The following is a description of a gene set: Mouse Gene Set: GOBP_REGULATION_OF_MYELOID_CELL_DIFFERENTIATION Any process that modulates the frequency, rate or extent of myeloid cell differentiation. species: Mus musculus, and this is the list of marker genes: Cnot4, Ifnb1, Lilrb4a, Iapp, Nme1, Acvr1b, Fstl3, Rb1, Ets1, Faxdc2, P4htm, Ppp3ca (protein phosphatase 3, catalytic subunit, alpha isoform), Rassf2, Cldn18, Il23a, Creb1, Acvr2a (NCBI Gene Id 11480), Gabpa, Tnfrsf11b, Myc, Klf10, Csf1, Nme2, Tnfsf11 (tumor necrosis factor (ligand) superfamily, member 11), Tmem178, Esrra, Fas, Abcb10, Gpr55, Cd101, Senp1, Ocstamp, Pou4f2, Id2, Mir223, Pira1, Itpkb, Zfpm1, Lyn, Rarg, Il5, Cul4a, Cd74 (CD74 antigen (invariant polypeptide of major histocompatibility complex, class II antigen-associated)), Pithd1, Hspa1b, Adipoq, Hcls1, Pias3, Mpl, Scin, Tesc, Inpp4b, Apcs, Stat3, Ppargc1b, Fbxw7, Rbp1, Gpr137b, Tescl, Hmgb1, Smap1, Car2, Ptpn2, Il20, Lox, Itgb3, Eeig1, Cd4, Lilrb4b, Cib1, Fshb, Gpr137, Tfe3 (transcription factor E3), Gsk3b, Stat1, Ceacam1, Clec2g, Ccl5, Jag1, Csf3, Med1, Sfrp1 (secreted frizzled-related protein 1), Isg15, Ripk1, Ctnnbip1, Rnf41, Meis1, Pou4f1, Ctr9, Nckap1l, Cebpb, Mef2c, Fgfr3, Rbfox2, Gpr68, Hax1, Zfp36l1, Zbtb7a, Mitf, Rptor, Mtor, Hmgb3, Ccr1, Hoxb8, Prmt1 (protein arginine N-methyltransferase 1), Prdm16, Stat5a, Gnas, Glul, Rcor1, Tmem64, Ccl3, Tjp2, Evi2b, Myb, Zbtb46, Mapk14 (NCBI Gene Id 26416), Pira12, Ptk2b, Hsf1, Leo1, Ndfip1, Tob2, Runx1, Gfi1b, Bmyc, Twist2, Tcta, Brd1, Lef1, Fbn1, Prxl2a, Qki, Tnfaip6, Traf6, Foxo3, Kat7, Il4, Ctnnb1, Lrrc17, Csf3r, Apc, Kitl, Prkdc, Nedd9, Dll1, Pilrb1, Skic8, Ccl21b, Rbm15, Ltf, Ror2 (NCBI Gene Id 26564), Fos, Fes, Ldb1, Mturn, Jun, Nf1, Itgam, Nfkbia, Il12b, Erfe, Fam210b, Cartpt, Trib1, Tnf, Thoc5, Ankrd54 (NCBI Gene Id 27619), Clec2i, Il17a, Csf1r, Tnfrsf11a, Ccl9, Stat5b, Fshr, Mafb, Evi2, Prkca (NCBI Gene Id 18750), Ccr1l1, Slc9b2, Gpr171, Foxp1, Hoxa9, B2m, Zfp36, Casp8, Inhba, Ifng, Thpo, Hoxa7, Gata2, Ikzf1, Pik3r1, Il3, Trem2, Tgfb1, Pla2g3, Dlk1, Ypel4, Lmo2, Dcstamp, Clec2d, C1qc (NCBI Gene Id 12262), Adam8, Kdm1a, Fadd, Rab7b (NCBI Gene Id 319567), Inpp5d, Klf13, Notch2, Asxl2, Mir125a, Hif1a, L3mbtl1, Pf4, Ninj1 (NCBI Gene Id 18081), Lif, Il34, Tyrobp, Paf1, Eif6, Acin1, Cdk6, Ubash3b, Gata1, Rara, Hoxa5, Spi1, Tal1, Cdc73, Hspa9 (NCBI Gene Id 23909), Setd1a, Hmgb2, Meis2